Given this list of marker genes Gm3985, Pak6, Armc7, B3galnt1, Klf3, Synpo2l, Abca9, Rfc1, Rufy2 (NCBI Gene Id 70432), Srf, Senp5 (SUMO/sentrin specific peptidase 5), Yipf4, Fut9, Rbms2, Rheb, Adam23, Cyp11b1, Npas3, Clic5, Asxl3, Ehd4, Insm2, Mfsd4b3-ps, Pdgfrl, Insyn2a, C1ra, Psg27, Me1, Akr1b1, Havcr1, Oprl1, Col19a1, Psg21, Dcaf10, Tcam1, Sntg2, here is a description of the gene set: from publication Chen Y, Wang X (PMID 31504780) studied in species Mus musculus Genes predicted to be targets of miRBase v22 microRNA mmu_miR_345_5p in miRDB v6.0 with MirTarget v4 prediction scores > 80 (high confidence targets). Mouse Gene Set: MIR_345_5P